The following is a description of a gene set: Neighborhood of MAGEA9 species: Homo sapiens Human Gene Set: MORF_MAGEA9 Neighborhood of MAGEA9 melanoma antigen family A, 9 in the MORF expression compendium, and this is the list of marker genes: PAXIP1, NFX1, MFN1, PIK3C2A, MPP3, RBMXL1, SYNJ2, CELA2B, RXRG, CHRNB4, LILRA4, CTRL, ADAMTSL3, MYOZ3, IL7, VIP, CNKSR1, F2RL1, DEPDC5, CYP4F2, SRPK3, SGPL1, KRT33A, TACC2, IFNA10, NMT2, CAMK4 (calcium/calmodulin dependent protein kinase IV), NTNG2, GNPAT, TBXT, POLR3F, SOAT2, ATF2, SLC17A3, THRA, MASP2, ZBTB40, ATP2B2, CXCL5, HOXB7, PHOX2B, RUNX2, EDN3, PAX9, RUNX1, RBMS3, BNIP1, ADAM20, CASP10, ETV3, SERPINA4, AQP7, HTR1E, P2RY10, TNFRSF25, MAGEA9, REPS2, NRTN, KRT34, PVR, SLC46A3, PRPS1L1, H3C6, OR2B6, GYS2, CDKL5, ITIH4, GPR15 (G protein-coupled receptor 15), RORB, PLPPR4, FNTB, MINDY2, THPO, WBP4, CDC42BPA, CCL16, CYP2C19, NR3C2, TTTY1, PLEKHB1, GRIK1, MDM2, OCM, CPB2, PHLDB1, SLC4A8, NF1, PDPN, CAMTA1, RB1CC1, TSHB, ATP10B, PCDHB17P, FGF18, TAF12, GPR19, ARL3, COL4A4, CHST1, BRD4, STAC, HOXC11, B4GALT6 (beta-1,4-galactosyltransferase 6), ERC2-IT1, CD6, ZNF157, DMPK, GLE1, HNF1A, MC5R, SLC6A2, MPZL2, ATP4B, CSRP3, DBT, CACNA2D1, ELAVL2, LPGAT1, EXOC4, PPP1R12B, CALN1, HCRTR2, TMEM26, ZP2, DMD, ABCB9, GCM1, MLLT10, KRT1, COLQ, TSPAN2, ABCC8, PDE4DIP, POFUT2, CNTN6, FAS, LPAR4, RSC1A1, EPHB2, OTC, CACNB1, CRYM, TIE1, MAP3K1, TBX5, MAP2, PRIM2, MSH3 (mutS homolog 3), GHRHR, CADM4, GPR171, BRCA1, ACKR1, CBLN1 (cerebellin 1 precursor), RPS6KA5, CA3, IL11RA, MSL3, ADCY3, RYR3, CCR3, STK17A, MAGI1, CYP2E1, SLC18A1, JADE3, CRHR1, VKORC1, HOXD4, AMMECR1, AOC4P, ANXA10, BARX2, UBE4B (ubiquitination factor E4B), SGCD, ATF6B, HEPH, ATP8B1, PRKCA, HTR1B, KCNA5, BMP10, PTPN20, RGS7, IFNW1, FIG4, ASB4, TNIK, AFF2, GLRA3, GJB5, CCN6, LECT2, ZNF132, BCL2L11, DGCR5, NRP2, ST8SIA1, APOBEC1, CTSB, CDC73, STAG1, PDE4D, LGI1, CPEB3, ERC1 (ELKS/RAB6-interacting/CAST family member 1), GCA, IL13RA1, CDH8, FRYL, PPP1R1A, ISL1, NHEJ1, GUCY2F, R3HCC1L, NR2F1, ELOVL6, IVL (involucrin), ITIH3, PIK3CB, SLC16A5, POU6F1, NXPE3, TRIM24, C6, ATP8A2, ULK2, GPR18, USP20, DRC3, SLC14A2, ARFGEF2, SLC17A7, SCAMP1, LRP6, ZNF33B, MPZL1, TPD52, S100A5, LORICRIN, COQ7, ENOX2, EDIL3, HABP4, PAX6, FGF2, KDR, SOCS6, PDCD1, TLL1, FZD5, CYP2D6, PAX7, JRKL, SPA17, MYH2, DNAJC16, CD3E, PRELID3A, CLOCK, GRIK5, GPATCH8, SLC15A1, ITGBL1, RREB1, POU6F2, ROR2, DRD1, AKAP3, NPFF, SPATA2, FUT1, SLC6A4, SMYD3, HMHB1, GUCY2C, GABRB2 (gamma-aminobutyric acid type A receptor subunit beta2), CMKLR2 (chemerin chemokine-like receptor 2), CD8A, ZSCAN26, PLA2R1, HSD3B2, KRT2, ZNF500, ERCC4, PHF10, ELL2, GRIP2, FSHR, PGM3, CYP11A1 (cytochrome P450 family 11 subfamily A member 1), VPS35L, FLRT2, PTPRB, USP46, ATP6V0A2 (NCBI Gene Id 7854), RBBP7, ZNF133, RNF24, CPZ, TANC2, SEMA6A, CEP162, GNG4, PSG1 (pregnancy specific beta-1-glycoprotein 1), PLXNA3, LILRA1, SLC4A3, NPAS2, IGKV7-3, KRT86 (keratin 86), TENM4, SCAPER, HTR2C, OR10H3, PTPRS, ADCYAP1, DAZL, FRY, IFNA2, POLR2K, ECM2, SUPT3H, ATXN3, ADRA1A, ZNF710, IFNA1, DAPK2, FOSL1, NR1I2 (NCBI Gene Id 8856), HTR3A (NCBI Gene Id 3359), F2RL3, PDE10A, SLC13A2, IFNA14 (interferon alpha 14), PART1, ESR1, SLC22A6, FBXL4, MYT1, KNG1, LRP4, BRINP3 (BMP/retinoic acid inducible neural specific 3), COX6A2, COL14A1, DDX52, STXBP5L, STARD5, KLRC4, LDLRAD4, NOS2, LDB3, CLCN3, IPO9 (NCBI Gene Id 55705), RAD51D, SIX6, ARHGEF12, SYT5, ZBTB14, IL13, COL8A1, COLGALT2, DNAJC22, ZNF200, FUT6, KPNA1, B3GNT3, MGA, TNK1, SPRR2C, PDE6A, PTEN, TFDP2, PCM1, ABCB1, SLC33A1, ZNF134, PPM1E, KRR1, ABO, NOVA1, PPP2R5B, SFRP4, KRT33B, TBX19, NCKIPSD, NEB, DPT (NCBI Gene Id 1805), PTPRR, ZNF202, TSSK2 (testis specific serine kinase 2), MON2, NFAT5, IL16, SLC17A1, FLT1, SLC26A4, TRIO, PSD, SLC2A1 (NCBI Gene Id 6513), IL4, MAP2K7, POLR1HASP, ZNF141, CDH4, NTPCR, GMPR, SULT4A1, SIM2, MAGEA8, FAM13A, COL19A1, LTBP4, ABCB10 (ATP binding cassette subfamily B member 10), CFH, GABRA1, CDR1, ZNF266, HAAO, NEDD4L, C1orf216, SCN7A, FGA